The following is a description of a gene set: Human Gene Set: GSE2706_LPS_VS_R848_AND_LPS_2H_STIM_DC_UP Toll like receptors (TLRs) sense microbial products and initiate adaptive immune responses by activating dendritic cells (DCs). Since pathogens may contain several agonists we asked whether different TLRs may synergize in DC activation. We report that in human and mouse DC TLR3 or TLR4 potently synergize with TLR7, TLR8 or TLR9 in the induction of selected cytokine genes. Upon synergistic stimulation, IL-12, IL-23 and Delta-4 are induced at levels 50-100 fold higher than those induced by optimal concentrations of single agonists, leading to enhanced and sustained TH1 polarizing capacity. Using microarray analysis we show that only 1.5% of the transcripts induced by single TLR agonists are synergistically regulated by combinations of TLR4 and TLR8 agonists. These results identify a combinatorial code by which DCs discriminate pathogens and provide (suggest) a rationale to design adjuvants for TH1 responses. Series_overall_design: 3 untreated, 3 treated with LPS at 2h, 3 treated with LPS at 8h, 3 treated with R848 at 2h, 3 treated with R848 at 8h, 3 treated with LPS + R848 at 2h, 3 treated with LPS + R848 at 8h from publication Napolitani G, Rinaldi A, Bertoni F, Sallusto F, Lanzavecchia A (PMID 15995707) species: Homo sapiens Genes up-regulated in comparison of dendritic cells (DC) stimulated with LPS (TLR4 agonist) at 2 h versus DCs stimulated with LPS (TLR4 agonist) and R848 for 2 h., and this is the list of marker genes: CCDC102A, CT55 (NCBI Gene Id 54967), GFRA4, CD37, TBR1, TMUB1, RPL10L, ORMDL1, CYB5D2, SLC39A13, WDR59 (NCBI Gene Id 80779), CCL16, RAB11B, NXPH3, LACRT, CEP126, DNAJB8, C1orf74, PSG7, PJVK, RBFOX2, NPHP1, KIR2DL3, WNT10B, ZNF304, GGTLC1, LINC00587, RGL3, ATP13A3-DT, CAPN15 (NCBI Gene Id 6650), ODF4, DBIL5P, HOXD4, ENSG00000257545, GPR35, SLC12A7, C1orf56, GALNT13, LAT2, CITED1, C17orf78, ELL2 (elongation factor for RNA polymerase II 2), MFAP4, CH25H, GATA6, ENSG00000236854, GRAMD1B, HLA-J, APOBEC2, VN1R4, PSMB9, NKX1-1, FAM163A, DRAXIN, ETNK2, LINC00628, AGFG2, LPCAT4, JAG1, CRNN, DNHD1, CASKIN1, HTR2C (5-hydroxytryptamine receptor 2C), CAMK1G, PLEK, C2CD4C, IL2RG, FAM83F, GPX5, ALKBH1, E2F4, DNAJC22, CAV2, ZNF280B, IRGC, CCDC33, KRTAP5-AS1, PATJ, TBRG4, IGKV1D-13, IL1RAPL1, NBPF8 (NCBI Gene Id 728841), MARVELD3, PTCSC1, PPOX, IGSF8, CDC37, AK7, SDK2, SLAMF1, BYSL, MRPS24, ZNF337, DEFT1P, P2RY2, SLC26A3, BCL2L12, LINC01101, ALDH1B1, WNT2, ZKSCAN7, ENSG00000274253, NAIF1, CLDN2, PLXNB3, ZNF646, NFKBIB, GKAP1, GRTP1, TYMS, C20orf203, TGFB1, CATSPER1, FOXI1, DUSP16, NEUROD4, TRMT2A, ITPRID1, PCDHB19P, APOBEC4, FOLH1, DNAH12, CIDEA, PPFIBP2, FREM2 (NCBI Gene Id 341640), SLC38A1, SCARNA2, CDKN2AIPNL, STK33, ANAPC1 (NCBI Gene Id 64682), SERTAD4BP, SLC25A28, LRRC8B, CDCA3, CRYM, GP1BA, PDE3B, FAM170B, RHBDL3, TRIP10, BORCS6, CCDC30, BTG4, H2AC4, PPP1R17, PLP2, MED12 (mediator complex subunit 12), TP53AIP1, DAGLA, GAPDHP62, MUC3A, FGF7, SH3GLB2, GSK3A, GSTM1, LAMC3, FHL3, SUN5, SPI1, RPS6KA4, GPR75, PCGF5, SERPINA6, YWHAEP7, STKLD1, SUGT1P3, CORIN, MEGF10, ANKS3, TGM3, ACTG2, NKAIN1, ZNF780B, LDB2, DHX37, LINC00028, TGM5, VIP (vasoactive intestinal peptide), CFAP92, EFCAB12, ABCF2, PPP1R14B, NIBAN3, ASGR1, RNASE11, RAPGEF4-AS1, RAB27A, ERC2-IT1, SDR42E1, LCE1B, TMEM67